Given this list of marker genes Atp2b2, Nppb, Gucy2f, Nppa, Gucy2g, Pde1a, Npr1, Gucy2d, Gucy1a1 (NCBI Gene Id 80637), Pde2a, Pde5a, Npr2, Nppc, Gucy2c, Gucy1b1, Rora, Gucy2e, Pde9a, Pde10a, here is a description of the gene set: The chemical reactions and pathways involving cyclic GMP, guanosine 3',5'-phosphate. species: Mus musculus Mouse Gene Set: GOBP_CGMP_METABOLIC_PROCESS